The following is a description of a gene set: Radiographic evidence of articular calcification that represent calcium pyrophosphate depositions in soft tissue surrounding joints and at the insertions of tendons near joints (Entheses/Sharpey fibers). Chondrocalcinosis Human Gene Set: HP_CHONDROCALCINOSIS species: Homo sapiens, and this is the list of marker genes: FXYD2, ATP7A, ALPL, GNA11, MEFV, NOTCH3, ANKH, GCM2 (glial cells missing transcription factor 2), CDC73, TNFRSF11B, TNFRSF1A, HYAL1, LMNA, ATP7B, SLC12A1, AP2S1, MEN1, PDGFRB, KCNJ1, WRN, CLCNKB, SLC12A3